Given this list of marker genes TLCD3B, XYLT2, PRPS1, CIB2, BCOR, CFAP418, SLC19A2, PHYH, CEP120, SOST, HCCS, KIAA0586, EXOSC9, CACNA2D4, TAT, EPM2A, SLC25A46, POLA1, CLN3, GUCA1A, RDH5, OAT (ornithine aminotransferase), TRAF7, NPHP4, HARS1, RIMS1, TRAF3IP1, ATP1A3, FGFR2, TBC1D24, PAK2 (p21 (RAC1) activated kinase 2), WAC, MT-CO3, MT-CYB, MT-TS2, CCND1, VRK1, COQ2, MT-CO1, POLG2, RPGR, ABCA4, AGTPBP1, HLA-B, LRP2, SUFU, TERT, AIP, LTBP2, COL17A1, MT-ND1, DUX4, AKT1, PPT1, NOD2, ST3GAL5, FLVCR1, CLCN7, PRPH2, KIF11, PEX7, PCYT1A, APOE, RHO, RAX2, OPA1, TTLL5, CARS2, LAMC3, MEN1, GJB6, SPTBN1, HMCN1, MKS1, GNA11, MERTK, CEP41, IQCB1, GATA2, ZNF469, POLG, SRD5A3, SEMA4A, EXOSC8, ANKRD55, TGFBI, CA2, EPRS1, C1QTNF5, FBN1, NF1, TEFM, MT-CO2, MT-ND2, GUCY2D, ESPN, PMPCB, SOX2, PAX6, SMARCE1, KARS1, CYSLTR2, MT-ND5, COL2A1, SF3B1, HLA-A, PRDM5, CLN8, CLN6 (NCBI Gene Id 54982), ADAMTS10, NPHP3, PEX13, SNX10, SON, NF2, ZNF408, CFH, SMCHD1, GNAQ, COX7B, BRAF, CFHR3, SMARCB1, COX6B1, SPATA7, HLA-DRB1, MT-ND4, CLRN1, TUBB3, PDGFB, SDCCAG8, MYOC, TPP1, TCOF1, ARSG, COL7A1, PITPNM3 (NCBI Gene Id 83394), HADHA, ARL3, NHS, PCDH15, ADAMTS17, DNAJC30, PTPN2, TCF4, IL2RA, USH1C, TEK, TFG, CDH23, ADGRV1, RLBP1, TRIM44, CRX, HSD17B10, RPGRIP1, HSD17B4, ALPK1, MMP1, GJB2 (NCBI Gene Id 2706), DRAM2, CHM, CYP1B1, PSAP, USH2A, KCTD7, MT-ATP6, ZEB1, ELMO2, CEP290, NPHP1, MT-TL1 (NCBI Gene Id 4567), CFHR1, TNFRSF11A, IL2RB (NCBI Gene Id 3602), DUX4L1, PLA2G6, CDHR1, SLC4A11, TREX1, PROM1, OPN1LW, BAP1, WHRN, PGK1, MT-ND4L, DCN, MT-TW, MECR, VCAN, TIMM8A, NEU1, MFN2, TINF2, ALMS1, RAB28, CFAP410, MT-ND6, LCA5, AIPL1, MFSD8, CACNA1F, NBAS, WDR19, P4HA2, FOXC1, BTD, LSS, NMNAT1, COL18A1, SMO, PNPLA6, CFI (NCBI Gene Id 3426), OPN1MW, ABCD1, RS1, TIMP3, CTSD, DNM1L, PTPN22, MT-TQ, PDZD7, CEP78, NOTCH3, NDUFS2, SLC52A2, COL4A1, POC1B (POC1 centriolar protein B), GALC, DNMT3B, ADAM9, ATXN7, COL8A2, INPP5E, SH3BP2, IFT140, C19orf12, UCHL1, UNC119, EFEMP1, ZNHIT3, STAT4, CYP4V2, FA2H, MYO7A, HMBS, KIAA1549, RP1L1, PIK3CA (phosphatidylinositol-4,5-bisphosphate 3-kinase catalytic subunit alpha), AGBL1, USH1G, CTNNB1, ATF6, MTTP, VHL, FRG1, EXOSC3 (NCBI Gene Id 51010), CNGA3, MT-TH, RDH11, CLN5, AHI1, MT-TF, NDUFB11, CD247, INVS, CEP164 (centrosomal protein 164), GNAS, CSPP1, here is a description of the gene set: Visual loss studied in species Homo sapiens Loss of visual acuity (implying that vision was better at a certain time point in life). Otherwise the term reduced visual acuity should be used (or a subclass of that). Human Gene Set: HP_VISUAL_LOSS